The following is a description of a gene set: Any process that increases the rate, frequency, or extent of the aggregation, arrangement and bonding together of proteins and RNA molecules to form a cytoplasmic mRNA processing body. Mouse Gene Set: GOBP_POSITIVE_REGULATION_OF_CYTOPLASMIC_MRNA_PROCESSING_BODY_ASSEMBLY studied in species Mus musculus, and this is the list of marker genes: Cnot2 (NCBI Gene Id 97648), Cnot6l, Cnot1, Cnot6, Pan2, Pan3